Given this list of marker genes Prkaa1, Chka, Prkaa2, Plin2, Pnpla2, Plin3, Kat5, here is a description of the gene set: Mouse Gene Set: GOBP_LIPID_DROPLET_DISASSEMBLY studied in species Mus musculus The disaggregation of a lipid particle into its constituent components.